The following is a description of a gene set: Human Gene Set: GOBP_AUTOCRINE_SIGNALING species: Homo sapiens Signaling between cells of the same type. The signal produced by the signaling cell binds to a receptor on, and affects a cell of the same type., and this is the list of marker genes: SERPINB3, S100A8, CD68, FZD1, HILPDA, CX3CL1, S100A9, CX3CR1